The following is a description of a gene set: Human Gene Set: GOBP_PHAGOSOME_MATURATION A process that is carried out at the cellular level which results in the arrangement of constituent parts of a phagosome within a cell. Phagosome maturation begins with endocytosis and formation of the early phagosome and ends with the formation of the hybrid organelle, the phagolysosome. species: Homo sapiens, and this is the list of marker genes: RAB7A, MREG, RAB39A, SYT11, TCIRG1, CORO1A, SRPX, TMEM175, P2RX7, VIPAS39, RAB31, MTMR4, RAB20, RAB34, RAB7B, CLN3, RAB43, SLAMF8, PLA2G5, RAB32, RAB14, SPG11, SLC4A7, SYT7, MYO7A, RAB38, VPS33B, PIKFYVE, ARL8B, MCOLN1, SLC9A9 (NCBI Gene Id 339579)